Given this list of marker genes LMNA, PCGF2, LBR, CCDC8, FUCA1, POP1, ZMPSTE24, NAA10, TBX5, DYM, KRAS (KRAS proto-oncogene, GTPase), CBL, TRPV4, ACAN, SPRED2, SOS1, FBN1, GUSB, LRP5, RIT1, KDELR2, OBSL1, TRAPPC2, SRCAP, BCOR, IDH1, PRKACA, RASA2, HRAS, CHST3 (NCBI Gene Id 9469), RAB5IF, RRAS, RRAS2, AHDC1, VPS33A, CILK1, TNFRSF11B, GATA4, MRAS, PTPN11, BMPER, PRKACB, KAT6A, MYH3, LZTR1, GPKOW, XYLT2, COL2A1, RAF1, BRAF, INTU, TRIP11, SOS2, WNT4, ACP5, MAPK1, P3H1, COL13A1, RMRP, CUL7, NRAS, RAB33B, EIF2AK3, WNT7A, BMP1, MAP2K1, here is a description of the gene set: Enlarged thorax Human Gene Set: HP_ENLARGED_THORAX species: Homo sapiens